The following is a description of a gene set: Human Gene Set: GOBP_T_HELPER_1_CELL_DIFFERENTIATION studied in species Homo sapiens The process in which a relatively unspecialized T cell acquires the specialized features of a T-helper 1 (Th1) cell. A Th1 cell is a CD4-positive, alpha-beta T cell that has the phenotype T-bet-positive and produces interferon-gamma., and this is the list of marker genes: TNFSF4, ANXA1, SPN, LEF1, MTOR, CD80, HLX, CRACR2A, JAK3, IL18R1, ASCL2, CCL19, TBX21, HMGB1, STAT4, RIPK2, SOCS5, RELB, TMEM98, STAT6, IL4R, SEMA4A, IL27, NFKBIZ